Given this list of marker genes Dusp9, Dusp6, Dusp7, Dusp10 (NCBI Gene Id 98270), Dusp16 (NCBI Gene Id 70686), Dusp8, here is a description of the gene set: Mouse Gene Set: GOMF_MAP_KINASE_TYROSINE_PHOSPHATASE_ACTIVITY Catalysis of the reaction: MAP kinase tyrosine phosphate + H2O = MAP kinase tyrosine + phosphate. studied in species Mus musculus